The following is a description of a gene set: from publication El Kasmi KC, Holst J, Coffre M, Mielke L, de Pauw A, Lhocine N, Smith AM, Rutschman R, Kaushal D, Shen Y, Suda T, Donnelly RP, Myers MG Jr, Alexander W, Vignali DA, Watowich SS, Ernst M, Hilton DJ, Murray PJ (PMID 17114459) IL-10 or IL-6 stimulation of control 129xC57BL/6 murine bone marrow derived macrophages in the presence of LPS. We used microarrays to detail the global programme of gene expression changes in response to IL-6 or IL-10 stimulation in the presence of lipopolysaccharide. BMDMs were isolated from control, IL-6-/-, and IL-10-/- mice on a 129XBL/6 mixed background mice and differentiated in the presence of CSF-1 for 6-7 days. Cells were scraped and plated in 6 well plates at 2x10e6/well. Cells were washed with complete DMEM and rested for 1-2 hr before stimulation with combinations of IL-10 (10 ng/ml), IL-6 (2 ng/ml) or LPS (100 ng/ml) for 45 min or 180 mins. Complete biological replicates were performed. studied in species Homo sapiens Genes down-regulated in bone marrow-derived macrophages: untreated (0 min) versus IL6 and LPS (45 min). Human Gene Set: GSE5589_UNSTIM_VS_45MIN_LPS_AND_IL6_STIM_MACROPHAGE_DN, and this is the list of marker genes: IL17RC, HAPSTR1, ZFAND5, HSD17B6, LGR4, PRPF3, DCUN1D3, TNK2 (tyrosine kinase non receptor 2), FUBP1, CLSTN1, LRRC20, PAQR9, KCNAB1, ASIC4, SLC22A4, NAA50, GFM2, TSPAN3, GAR1, TSFM, NAA35, RAD23B, FTSJ3, ACER3, MARCHF6, ATP1A3, VEZT, NOL11, CNOT11, DNAJA3, CHMP1B (NCBI Gene Id 57132), AEN, CLBA1, MARS1, RTF2, METTL3, METTL27, C11orf58 (NCBI Gene Id 10944), S100A6, WLS, OTUB1, HCFC2, CCDC134, ASCL3, DPP8 (dipeptidyl peptidase 8), PDGFA, HMG20B, CSNK2B, RNH1, VCPKMT (NCBI Gene Id 79609), SCLY, IGF2BP3, GFM1, INIP, MRPL27, FIBP, AP2M1, LARP4B, PGK1, PDXDC1, SPHK1, REL, KIF5B (NCBI Gene Id 3830), EMP2, OTUD3, ECE2, CDK20, CAMK2N1, TANGO6, PPP1R7, MPDU1, STXBP3, CHP1, AHCYL1, ARHGEF12, CLNS1A, DDX21, ZSWIM1, TCERG1, ACOT9, FPGT, PHOSPHO1, TMEM217, PLEKHO2, DDX31, PLEKHA3, SMARCAD1, GPRC5B, GFUS (GDP-L-fucose synthase), PWP2, PSMC3, MINDY1, CMPK1, CHMP7 (charged multivesicular body protein 7), PRKAA2, GPATCH4, PHLDA3, SS18L2, ELL2, P2RY14, TMEM126B, AGPAT4, COX17, GALNT1 (NCBI Gene Id 2589), DECR1, SGTB, ARL6IP5, KAT14, VPS53 (NCBI Gene Id 55275), GARRE1, DYNC1LI1, INTS15, ADAMTS1, TAF10, MICALL1, HIPK2, TMEM144, TMEM245, AKIRIN2, B3GLCT, LAMA5, KMT5A, INPP5A, RNF4, ACTN1, TARBP2, DGKE, MRPL20, VDAC3, SLC25A3, ACOT11, EEF1A2, ATP6V0A2, QNG1, CMBL, NR1H3, EPN2, ESF1, BTBD3, HNRNPLL, PLIN2, IFT43, HADHB, YME1L1, MGAT4B, UGP2, TUBG1, SLC41A2, TBRG4, VKORC1L1, DUSP11, AVEN, DYNLL1, PKLR, KLHL13, TANC2, COA8, RARRES1, ANGPTL3 (angiopoietin like 3), PI4KA, PTP4A2, PDCD6, GTF2H3, ITPR1, STUB1, CLDND1, GRPEL1, HEBP1, CHCHD10, PKDCC, B4GALT5, PDHB, AGA, RCE1, TSPAN14, NUP50, RRP12, SEC63, PPA1, MMGT1, UTP18, MYL7, HSD3B7, KALRN, FBXO32, CHORDC1, MALT1, NAA38, POLR2M, ZNF697, SLC28A2, TACC2, ERO1A, CREB3L1, MARCHF2, COQ3, FGD6, ZFP57, SLC39A6, UGDH